Given this list of marker genes CALCB, ADM, RAMP2, RAMP1, CALCA (NCBI Gene Id 87044), CALCRL, RAMP3, CALCR, ADM2, IAPP, here is a description of the gene set: The calcitonin peptide family comprises calcitonin, amylin, calcitonin gene-related peptide (CGRP), adrenomedullin (AM) and intermedin (AM2). Calcitonin is a 32 amino acid peptide, involved in bone homeostasis (Sexton PM et al, 1999). Amylin is a product of the islet beta-cell (Cooper GJ et al, 1987), along with insulin and probably has a hormonal role in the regulation of nutrient intake (Young A and Denaro M, 1998). Adrenomedullin (AM) is a ubiquitously expressed peptide initially isolated from phaechromocytoma (a tumour of the adrenal medulla) (Kitamura K et al, 1993). Both AM and AM2 (Takei Y et al, 2004) belong to a family of calcitonin-related peptide hormones important for regulating diverse physiologic functions and the chemical composition of fluids and tissues.<br>The receptor family for these peptides consists of two class B GPCRs, the calcitonin receptor (CT) and calcitonin receptor-like receptor (CL) (Poyner DR er al, 2002). Whilst the receptor for calcitonin is a conventional class B GPCR, the receptors for CGRP, AM and amylin require additional proteins, called the receptor activity modifying proteins (RAMPs). There are three RAMPs in mammals; they interact with the CT receptor to convert it to receptors for amylin. For CGRP and AM, the related CL interacts with RAMP1 to give a CGRP receptor and RAMP2 or 3 to give AM receptors. CL by itself will bind no known endogenous ligand. Reactome Pathway: Calcitonin-like ligand receptors part of: Class B/2 (Secretin family receptors) species: Homo sapiens